The following is a description of a gene set: Catalysis of the transfer of a myristoyl (CH3-12-CO-) group to an acceptor molecule. Human Gene Set: GOMF_MYRISTOYLTRANSFERASE_ACTIVITY species: Homo sapiens, and this is the list of marker genes: NMT2, SCP2, ZDHHC17, ACAA1, HADHB, ZDHHC15, ZDHHC7, ZDHHC2, NMT1, ZDHHC3, ZDHHC20